Given this list of marker genes SORL1, PDCL3, EPPK1, ZDHHC19, CELF1, here is a description of the gene set: studied in species Homo sapiens The perinucleolar compartment (PNC) is a subnuclear structure associated with, but structurally distinct from, the nucleolus. The PNC contains large amounts of the heterogeneous nuclear ribonucleoprotein complex (hnRNP) called hnRNP 1 (PTB). Many RNA binding proteins as well as RNA polymerase III transcripts are highly enriched in this compartment. PTB and pol III transcripts are required for the integrity of the PNC. Human Gene Set: GOCC_PERINUCLEOLAR_COMPARTMENT